Given this list of marker genes ENSG00000288330, PNKD, EP300, CP, ATXN8OS, CREBBP, GLI3, LRIG2, PDE2A, PLPBP, PANK2, ALDH7A1 (aldehyde dehydrogenase 7 family member A1), GATAD2B (NCBI Gene Id 57459), here is a description of the gene set: Facial grimacing studied in species Homo sapiens Human Gene Set: HP_FACIAL_GRIMACING